Given this list of marker genes Bclaf1, Hoxc8, Pcdha1, Kcna4, Crim1, Adamts5, Cnksr2, D430041D05Rik, Mturn, Morc3, Rufy3, Btbd3, Gls, Clasp1, Cpeb4, Anapc16, E2f7, Dram1, Arl13b, Klhl5 (NCBI Gene Id 71778), Tgfbr1, Srsf7, Ttc39b, Klhl29, Scamp2, Kcnh1, Slc2a3, Nexmif, Dennd4c, Nr6a1, Adamts1, Psap (NCBI Gene Id 19156), Tulp4, Zfp14, Spry4, Fnip2, Pdcd6ip, Atg5, Clip1, Lrrc32, Plcl2, Ago2, Ythdf3, Ythdc2 (NCBI Gene Id 70219), Dnajc13, Adamtsl1, Ralgapb, Clasp2, Tmeff1, Acvr1c, Nwd2, Syne1, Prom2, Rnmt, Plekhj1, Med8, Xpo7, Zfp36l2, Txndc12, P2ry10, Qser1, Cbfa2t3, Naa15, Slf2, S1pr1, Tns1, Spice1, Gm14391, Pknox2, Specc1l, Ss18l1, Jarid2, Zfp971, Gm20939, Tmem94, Zfp850, Lyrm1, Cdyl, Zfp1008, Zbtb43, Sec24a, Umad1, Cecr2, Hoxa11, Zfp965, Cfap90 (NCBI Gene Id 69315), Dlgap2, Stim2, Aldh3a2, Cnksr3, Jade2, Cacnb2, Lmo1, Zfp825, Sin3b, Pcdhac1, Epha4, Peak1, Zfp280d, Gm14322, Itsn2, Sim1, Stxbp6, Brd1, Ano1, Ube2b, Atp2b2, Klhl42, Usp33, Tada2b, Gskip, Gm6710, Zfp930, Hibch, Mier3, Atxn1, Cpsf6, Nfat5, Pcdha7, Ubl3, St8sia4, Prox1, Mtf2 (NCBI Gene Id 97205), Pcdha4, Grik2, Birc6, Trim71, Zfp810, Rbm26, Drd1, E2f5, Htr1f, Zfp975, Rnf182, Pi15, Dmxl2, Lhx9, Ccnj, Zfp800, Spty2d1, Ccp110, Ncald, Nr2c2 (nuclear receptor subfamily 2, group C, member 2), Klf15, Eya3, Epc2, Tecpr2, Apba1, Dnaja4, Cdc42bpa, Mpi, Mdh1b, Rps6ka3, Dido1, Trak1, Zfp317, Nr3c1, Ddx55, Zfp704, Htr1a, Trub1, Kpnb1, Jdp2, Zdhhc7, Etl4, Mb21d2, Acsl4, 2010315B03Rik, Zbtb7a, Gatm, Fign, Esco1, Agfg1, Usp42, Slc4a10, Hycc2, Zfp781b, Pax9, Dclk1, Mycbp2, Cep97, Ahnak, Slc25a37, Zfp967, Rbm46, Gm14296, Zfp970, Tnfrsf11b, Ippk, Baz2b, Ptbp3, Zfp966, Patl1, Zfp1009, Zic2, Abi3bp, Mboat2, 5730507C01Rik, Lrba, Sec24c, Slitrk1, Mamdc2, Ppip5k2, Zfp36l1, Fmnl2 (formin-like 2), Dio2, Gigyf1, Tsc22d2 (NCBI Gene Id 74514), Nr4a3, Mfsd6, Pcdha9, Pcdha5, Map4k4, Zdhhc17, Clec10a, Tspan13, Rorb, Ino80d, Glrb, B4galt1, Cdon, Abtb2, Wdr82, Rex2, Ipo8, Zfp973, Tab3, Grb10, Prtg, Zfp867, Pcdha2, Thrb, Adam11, Oxsm, Sfmbt1, Phtf2, Hipk3, Palb2, Nab1, Zfp619, Zfp935, Gabra1, Rbbp7, Zfp120, Sgpp1, Zfp97, Hmbs, Lclat1, Fam3c, Mtx3, Pcdhac2, Slc7a13, Trim2 (tripartite motif-containing 2), Msantd3, Rad21, Ccdc122, Dlg2, Pcdha12, Septin8, Lemd3, Pou2f1, Igdcc3, Gpr22, Prrc2c, Creb1, Hey2, Ap1s3, Scyl3, Lin28b, Zfp600 (zinc finger protein 600), Pnisr, Rai1, Ttl, Esm1, Kmt2a, Nr1d2, Pcdha6, Bhlhe40, Ap4e1, Tnfsf10, Gm14325, Nucks1, Cpne2, Atp2b1, Adcy9, Greb1l, Crebrf, Nek7, Wnk1, Cluh, Rala, Gm6712, Ipmk, Atf7ip2, Dcbld2 (NCBI Gene Id 73379), Cpd, Tcerg1, Carf, Mmp14, Pcdha3, Spire1, Ncoa2, Bend3, Nova1, Pcdha11, Pdap1, Gse1, Armcx3, Zfp101, Zfp980, Grm5, Lrrc8e, Mfsd1, Mapk1, Zfp936 (NCBI Gene Id 668620), Zbtb4, Kcnq5, Arf6, Dusp6, Lox, Bcl2l11, N4bp2, Afg3l2, Lif, Tbc1d4, Taok1, Ttpa, Tent4b, Slc35f3, Prkcd, Togaram1, Pcdha8, Dock4, Sowaha, Schip1, Ppfia1, Zfp869, Pi4k2b (NCBI Gene Id 74082), Tbc1d1, Zfp976, Phlda1, Phf20l1, Zbtb41, Wsb1, Limch1, Mlf1, Prdm4, Atp2b3, Ppp3r1, Sox6, Spink2, Ercc8, C2cd5, Carm1, Zfp931, Rsad1, Rnf34, Cntn4, Gpsm1, Il1a, Adamts6, Pbx1 (pre B cell leukemia homeobox 1), Ap1g1, Pabir2, H2-K1, Zfp960, Kmt2c, Ankrd44, Tmem165, Osbpl3, Cbx7 (chromobox 7), Adarb1, Pcdha10, Gfpt1, Zfp808, Hoxa1, Mtpn, Cblb, Klf6, Smap1, Gata6, Gpd1l, Pals1 (protein associated with LIN7 1, MAGUK family member), Golga1, Dnajc21, 1700066M21Rik, Tnf (tumor necrosis factor), Zfp951, Gpd2, Tnfaip1, Papolg, Chic1, Zfp934, Rabgef1, Gm14326, Rassf1, Ubp1, Ercc5, Hsp90b1, Etv6, Heca, Nmnat3, 2210418O10Rik, Slc25a36, Larp4, Rps6kb1, Ddx3x, Esr1, Acvr2b, Tmed4, Rlim, Sema4g, Zic3, Zfp458, Ssx2ip, Mideas, Man2a1, Fbxo33, Entpd6, Rassf8, Cdc40, Iqschfp, Hic2, Zfp958, Nkain2, Nipal4, Cyp2c39, Notch2, Mybl1, Rin2, Nus1, Zfp780b, Sik3, here is a description of the gene set: Mouse Gene Set: MIR_181A_5P from publication Chen Y, Wang X (PMID 31504780) Genes predicted to be targets of miRBase v22 microRNA mmu_miR_181a_5p in miRDB v6.0 with MirTarget v4 prediction scores > 80 (high confidence targets). studied in species Mus musculus